Given this list of marker genes PITPNC1, HMGXB4, NSG1, TGFB2 (NCBI Gene Id 7042), UBE2Q1, LIN28B, SDC2, PTPN4 (protein tyrosine phosphatase non-receptor type 4), PPM1A, ADAMTS18, RASA1, C6orf120, MFSD6, DYNC2H1, UTY, C1orf21, PIK3R1, RALGAPA1, RIMKLB, XIRP2, PCSK2, ETV1, ARHGEF10L, HDGFL3, DGKH, SYBU, IL36G, WRNIP1, FAM3C, OSBPL11, TMX1, MAP1LC3B, NANP, GRIK2, SYNJ1, ABCB1, BHLHE22, TNRC6B, ELK4, RPEL1, BAZ2B, CHMP2B, KIF3B, CNTN4, ZNF230, GLI3, GBP5, CEP70, FAM184A, BMP10, DYNC1LI1, BTBD3, CASP7, MPDZ, RAB31, PRLR, ERLEC1, TFAP2A, SLF2, TSHZ1, TNRC6C, BAHCC1, TMEM167B, CACNA2D1, KLHL3, PIBF1, YWHAE, SERTAD2 (SERTA domain containing 2), VIP, RAB6B, BLOC1S2, NAA16, JAK1 (NCBI Gene Id 3716), CAPS2, TMEM108, KCNQ3, ATAD1, YTHDC2, EDIL3, INO80D, ARX, RBPJ (NCBI Gene Id 51580), KLC1, RNF44, YWHAQ, MACF1, SHPRH, FBXW7 (F-box and WD repeat domain containing 7), RGS4, ARHGAP23, TMEM39A, TLR6, GUCA1B, SORL1, PPFIA2, CFAP47, PDLIM5, PNRC1, DNAJB4, CNOT1, SIRT5, CA8 (NCBI Gene Id 767), HOMER1, SLC26A7, EPB41L5, PLCXD1, SOCS6, ABCA5, BCLAF3, UNKL, PROX1, KLF7, CLEC4C, SLC30A5, MECP2, CLOCK (NCBI Gene Id 9575), LINC03106, CRYZ, KRIT1, CKS2, RICTOR, CXCL2, NR2C2, MLLT3, VAV3, TMED10, SMAP2, RBP3, LRRC34, ACE, LRP4, RNF216, SOX21, PDGFRL, KCTD8, EBF2, U2SURP, NET1, KCNMB2, ZSWIM6, GABPA, MAGEA2, CRADD, NR3C1, BTAF1, PREX2, PKN2, BCL6, PRPF39, EPCAM, CYB5A, ST8SIA4, MSL1, RPAIN, METAP1, DSC3, KITLG, DENND4A, COL4A1, TMCC1, INTS2 (NCBI Gene Id 86656), PPM1K, GRM3, TMEM196, ZYG11B, YWHAB, PCDH18, CCDC120, DLAT, DIP2B, KLHL23, ZNF326, GUCY1B1, STYK1, PGS1, PIK3CA, SVEP1, PM20D2, ACSL3, CALCA, PSD3, R3HDM1, GOLGA7, EML4 (EMAP like 4), KHDRBS2, LAMB4, PDIK1L, TNPO1, GABRB3, REV3L, ZNF367, DACT1, UBE3A, RNF34, SYT4, ZFAND5, CREBZF, ZBTB14, WDR47, EYA4, IARS1, HERC2, NAP1L2, JAG2, PCSK5, FRY, PRKAA2, COL21A1, NIN, LYAR, ELMOD2, POLR2F, ADAMTS17, RBAK, DIPK1C, GPR137C, PTEN, VAMP2, NLK, PSIP1, GLUD1, UCK2, FBXO11, PHF13, TMCO1, TMPRSS12, ANKRD45, STEAP2, FAM135B, ZC3H6, FAT3, PCBP1, PHIP, VAX1, SYTL2, PAXBP1, GPR173, HYCC2, KBTBD2, ALDH1L2, TOP1, IL17C, DCLK1 (doublecortin like kinase 1), MOSPD1, TNS1, MYO9B, SNAP23, SLC44A5 (solute carrier family 44 member 5), BEND6, RBM12, PIK3CB, CNOT2, GABRB2, TOX3, NHS, GALNT4, TBC1D12, TNFRSF19, EPS8L2, CACNB4, PPIL6, PEX5, AQR, ZFY, MERTK, PPAT, UBR5, EBF1, LRRIQ4, ACAT2, CREB1, ADCYAP1, EPHA5, CCDC62, L2HGDH, ARAP2, CHEK1, ERMN, PGAP1, CDYL2, KDM2A, STK3, C8orf34 (chromosome 8 open reading frame 34), ZEB1, KCTD7 (NCBI Gene Id 154881), LEMD3, ZSWIM5, ZNF518B (NCBI Gene Id 85460), RAPH1, GRID1, FOXN3, DLGAP4, CLVS1, PCMT1, SLC9A6, KIT, SESN3, ARID2, DLX5, TRIM33, ANGPT1, BAG4, SMC6, TRA2B, PWWP2A, AFF4, DIAPH2, ARFGEF2, SGTB, CPSF6, DOCK4, MBIP, SEMA6D, CLCN4, CENPI, ARHGAP24, HNRNPA1, ZBTB5, ANO5, ERP44, KDM6A, PTPRR, RANBP9, TMPRSS15, ANKRD11, CLEC4E, MAGEA2B, ZFHX3, CFAP43, ACTR3, DTL, SFRP1, USP3, UBTF, SNRPD1, EVI5, XRN1, ZNF519, CIAO2A, RBM25, BNC2, BRIX1, KRTAP24-1, NUP62CL, C21orf91, STXBP3, MAP3K15, FOXJ3, LGI1, ZNF334, TBK1, NUBPL, MAGEB16, FUT9, USP33 (ubiquitin specific peptidase 33), SLC44A1, DCUN1D4, AEBP2, NREP, NUFIP2, DEFB134 (NCBI Gene Id 613211), IRS1, GUF1, AUH, ZNF670, MAX, ITPRID2, GORAB, PDS5A, WDR26, FMNL2, SLC45A2, PAIP1, DNAJC22, ZCCHC24, VSTM2A, ANKRD40, KLHL9, EIF2B1, THUMPD2, MEX3B, LMO7DN, CFL2, ZC3H12C, SERP1 (NCBI Gene Id 27230), ZNF415, PLCB4, KLF15, AZIN1 (NCBI Gene Id 51582), LRRTM4, ZNF680, GOLGA8M, FGF4, INTS14, YEATS2, SLC6A1, SNAP91, SGIP1, NUS1, BRD1, PKD2, CCDC32, KLHDC1, UBR1, ANKFY1, RUNX2, MRS2, MARCHF6, ABI1, RAB9A, RPS6KA3, MGAT4A, CSNK1D, NR1D2, here is a description of the gene set: species: Homo sapiens Genes predicted to be targets of miRBase v22 microRNA hsa-miR-466 in miRDB v6.0 with MirTarget v4 prediction scores > 80 (high confidence targets). Human Gene Set: MIR466 from publication Chen Y, Wang X (PMID 31504780)